Given this list of marker genes NPPA, HIPK3 (homeodomain interacting protein kinase 3), PDCD4, PTPN22, SERPINB3, DNAJA1 (DnaJ heat shock protein family (Hsp40) member A1), AIDA, MAPK8IP1, here is a description of the gene set: Human Gene Set: GOBP_NEGATIVE_REGULATION_OF_JUN_KINASE_ACTIVITY Any process that stops, prevents, or reduces the frequency, rate or extent of JUN kinase activity. studied in species Homo sapiens